Given this list of marker genes ECE1, NRP1 (NCBI Gene Id 8829), EDNRA, NPTX1, NPR2, EDN1, ITGA4, SEMA3A, NTRK1, COL25A1, here is a description of the gene set: species: Homo sapiens Human Gene Set: GOBP_AXONOGENESIS_INVOLVED_IN_INNERVATION The neurite development process that generates a long process of a neuron, as it invades a target tissue.